Given this list of marker genes CCR1, FES, TGFB1, QKI, TMEM178A, TOB2, PIK3R1, FOS, EVI2B, TCTA, TLR3, IRF7, MTOR, CREB1, ERFE, CALCA, DCSTAMP, FSTL3, APCS, RIPK1, MIR223, CAMK4, MIR125B1, TM4SF19, NF1, PRDM16, GPR55, UBASH3B, LILRB4, CUL4A, ADIPOQ, OCSTAMP, CD4, LTF, TAOK3, TAL1, TRIB1, INHBA, FADD, IL23R (interleukin 23 receptor), INHA, TESC, IL5, CD74, NDFIP1, TNFRSF11B, CLDN18, POU4F1, IL12B (interleukin 12B), PRXL2A, HLA-DRB1, MIR145, TFE3, KLF10, PTPN2, SLC9B2, HCLS1, MYC, TRAF6, CTNNB1, CDK6, FSHB, RPTOR (NCBI Gene Id 654218), GATA2, ZFPM1, GPR68, PLA2G3, LRRC17, STAT5A, CASP8, SFRP1, IL20, TLR4, TNFAIP6, LILRB1, MITF, PPP3CA, RUNX1, PF4, KITLG, C1QC, FSHR, ZNF675, TYROBP, IL17A, MIR486-1 (microRNA 486-1), ZFP36L1, CEBPB, NOTCH2, TNFRSF11A, ACIN1, ZBTB46, RASSF2, IL23A (NCBI Gene Id 51561), HOXA7, INPP5D, CARTPT (NCBI Gene Id 9607), LEF1, CCL3 (NCBI Gene Id 6348), CD101, LILRB3, LYN, IFNG, GPR137, BGLAP, EEIG1, TMEM64, FBXW7, CSF1, NEDD9, FOXP1, MAFB, FBN1, GPR137B, ID2, TNF, RARA, TREM2, CEACAM1, PPARGC1B, POU4F2, IAPP, HSF1, RB1, PRKCA, HAX1, CTNNBIP1 (NCBI Gene Id 56998), IL4, LIF, IL34, TNFSF11, PIAS3, here is a description of the gene set: Human Gene Set: GOBP_REGULATION_OF_MYELOID_LEUKOCYTE_DIFFERENTIATION Any process that modulates the frequency, rate, or extent of myeloid leukocyte differentiation. species: Homo sapiens